Given this list of marker genes SRSF10, LEMD3 (LEM domain containing 3), ERC2, ADNP2, TOGARAM1, MORF4L2, CABP7, MEIS2, CERS1, NRXN1, TBX15, PHF20, PRDM8, CAMK2G, MORF4L1, NR4A3, IRF2BPL (NCBI Gene Id 64207), ZEB2, DGKH (NCBI Gene Id 8524), SRSF1, here is a description of the gene set: studied in species Homo sapiens Genes having at least one occurence of the motif ATGCACG in their 3' untranslated region. The motif represents putative target (that is, seed match) of human mature miRNA hsa-miR-517b (v7.1 miRBase). Human Gene Set: ATGCACG_MIR517B